The following is a description of a gene set: species: Homo sapiens Human Gene Set: GOBP_REGULATION_OF_WOUND_HEALING_SPREADING_OF_EPIDERMAL_CELLS Any process that modulates the frequency, rate or extent of wound healing, spreading of epidermal cells., and this is the list of marker genes: MIR221, MTOR, PHLDB2, HTN1, FERMT2, CLASP2, FIGNL2, CLASP1, FERMT1, RREB1, PTEN